The following is a description of a gene set: species: Homo sapiens Human Gene Set: DURANTE_ADULT_OLFACTORY_NEUROEPITHELIUM_BOWMANS_GLAND from publication Durante MA, Kurtenbach S, Sargi ZB, Harbour JW, Choi R, Kurtenbach S, Goss GM, Matsunami H, Goldstein BJ (PMID 32066986), and this is the list of marker genes: CXCL17, LTF, ODAM, SLPI, CLDN10, HP, TCN1, ELAPOR1, GSTA1, PI3, S100A1, GPX3, LYZ, RNASE1, BPIFB1, FDCSP, STATH, ZG16B, PIGR, PPP1R1B, SCGB3A1, PIP, VMO1, LCN15, XBP1, LRRC26, BPIFB4, LCN2, NDRG2, BPIFA1, C6orf58, DMBT1, AZGP1